Given this list of marker genes Cpt2, Acads, Slc27a6, Acsl3, Acsl1, Fabp4, Slc27a2, Echs1, Acat1, Eci1, Cpt1b, Acadvl, Slc27a1, Decr1, Acsl4, Hadhb, Fabp1, Acadm (acyl-Coenzyme A dehydrogenase, medium chain), Fabp7, Slc27a3, Cpt1a, Acadl, Acsl6, Slc27a5, Slc27a4, Cd36, Acsl5, Fabp2 (fatty acid binding protein 2, intestinal), Hadh, Slc25a20, Hadha, Fabp3, here is a description of the gene set: Mouse Gene Set: WP_FATTY_ACID_BETAOXIDATION_STREAMLINED species: Mus musculus Fatty acid beta-oxidation (streamlined)